The following is a description of a gene set: studied in species Homo sapiens Human Gene Set: GOMF_ARACHIDONATE_MONOOXYGENASE_ACTIVITY Catalysis of the incorporation of one atom from molecular oxygen into arachidonic acid and the reduction of the other atom of oxygen to water., and this is the list of marker genes: CYP4F2, CYP2C18, CYP2S1, CYP2B6, CYP2C9, CYP2A6, CYP2J2, CYP2A13, CYP2C8, CYP2A7, CYP4A22, CYP4F12, CYP2F1, CYP2E1, CYP4A11, CYP4Z1, CYP1A1